Given this list of marker genes Enox1, Ndufa10, Ndufs8, mt-Nd1 (mitochondrially encoded NADH dehydrogenase 1), Nqo1, mt-Nd6, Ndufa9, mt-Nd4l, mt-Nd2, Ndufb7, mt-Nd3, Ndufa2, Ndufs7, mt-Nd4, Ndufv1, Aifm1, Ndufv2, Ndufs2, mt-Nd5 (NCBI Gene Id 78362), Ndufs3, Ndufs1, Ndufs4 (NADH:ubiquinone oxidoreductase core subunit S4), here is a description of the gene set: species: Mus musculus Catalysis of the reaction: NADH + H+ + acceptor = NAD+ + reduced acceptor. Mouse Gene Set: GOMF_NADH_DEHYDROGENASE_ACTIVITY